Given this list of marker genes Lrrk2, Egfr, Laptm4b, Apoe, Pmel (premelanosome protein), Cd63, here is a description of the gene set: Mouse Gene Set: GOCC_MULTIVESICULAR_BODY_INTERNAL_VESICLE studied in species Mus musculus A membrane-bounded vesicle wholly contained within a multivesicular body.